Given this list of marker genes ADAM19, FOSL1, STX3, PLEKHB2, NUCB1, INO80E, ZFAND2A (zinc finger AN1-type containing 2A), ZFHX3, CYSTM1, APMAP, IFNGR2, MRPL21, NEK6, NTSR2, HSP90B1, NUDT9, ACYP1, CASP7, PFKL, HLA-DMA, TSSC4, TUBB6, TXN, ANXA5, ITGAE, TNFRSF1A, NPC2, SCARB1, EIF6, TCIRG1, PDE1B, RPS11, REEP5, MOGS, ODC1, PSMB9, RALA, ITCH, SLC12A7, CSF2RA, DOCK5, GIMAP4, RNF145, DHRS1, RAMP1, SFTPD, DTL, PRM3, UBE2E1, SEMA4F, LSR, CD6, GSTT2 (NCBI Gene Id 91334), AIFM1, ISOC1, PSAP, AMACR, RAB8B, RAB11A, GALK2, ACP6, ERBB4, GRPEL1, MAN1B1, APOC1, HPCAL1, SH3BP2, BOLA2, ALDOC, CMTM7, GRN, RRM2, BTRC, BMP4, PLD4, SLC25A20, DPAGT1, ARL1, FBXW2, MDM2, CRABP2, PHLDA1, CAPNS1, ACTN2, SPP1, ARFRP1, UQCRB, RRBP1, CD81, TFR2, KEAP1, ARFGAP3, CADM1, FNDC3A, SHC1, NABP1, TYK2, KCTD10, GPX3, PTPRB, TENT5C (terminal nucleotidyltransferase 5C), PTGIS, EPHA3, RFXANK, SEZ6, CCN3, DYNC1I1, RGS10, LDHB, PPIB, SLC22A5, OGFR, KIF3C, PTAFR, CETN1, PTCD2, CDK5, LAPTM4B, AANAT (aralkylamine N-acetyltransferase), FGF5, ISYNA1, RALB, TMEM30A, NUMB, MAP1B, CKS1B (NCBI Gene Id 88475), PRKCSH, SEC61G (SEC61 translocon subunit gamma), H1-3, DNAJC15, AFF2, RCE1, AGPAT3, MPRIP, NAGA, GCLC, DNAJC3, SEPTIN6, OSER1, PEX7, PSMB10, EDEM2, PI4K2A, CFL2, TRIO, TGFBI, UTP3, PDIA3, RNF19B, APRT, CMTM6, HLA-DMB, COG5, UNC119B, PSMB8, ANXA8, DTD1, SLC11A1, SOD2, CST3, NCKAP1L (NCK associated protein 1 like), KRTAP19-5, PPP1R12C, CNTFR, GNAZ, MERTK, MACROH2A1, HLTF, TPGS1, RPL28, FUCA1, CNIH1, XCR1, CBR3, GFUS, CASP9, MAP4K1, RPL13A, IL15, CDK14, UNC93B1, GALC, LMNB1, PKIB, TUBA3C, FKBP1A, SSR3, MPEG1, PLGRKT, DEGS2, PABPC1, BID, ECE1 (endothelin converting enzyme 1), PFKP, ATN1, LAMTOR3, KAT2A, PSME1, ATP5PO, REXO2, here is a description of the gene set: species: Homo sapiens from publication Edwards AD, Chaussabel D, Tomlinson S, Schulz O, Sher A, Reis e Sousa C (PMID 12816982) The functional relationships and properties of different sub-types of dendritic cells (DC) remain largely undefined. We used a global gene profiling approach to determine gene expression patterns among murine splenic CD11c high DC subsets in an effort to better characterise these cells. Genes up-regulated in comparison of CD8 dendritic cells (DC) versus CD4- CD8- DCs. Human Gene Set: GSE339_CD8POS_VS_CD4CD8DN_DC_IN_CULTURE_UP